The following is a description of a gene set: Abnormal hemidiaphragm morphology Human Gene Set: HP_ABNORMAL_HEMIDIAPHRAGM_MORPHOLOGY species: Homo sapiens, and this is the list of marker genes: NR2F2, GATA6, NDUFAF5, ALDH1A2, WT1 (NCBI Gene Id 7490), GNE, CDC42BPB